Given this list of marker genes Casc3, Ddx39a, Nxf7, Srsf5, Nup155, Nup133, Srsf3, Thoc6, Magohb, Alyref, Nup210, Nup42, Nup85, U2af2, Rnps1, U2af1l4, Nxf2, Nup54, Magoh, Upf3b, Seh1l, Cdc40, Ndc1, Sarnp, Thoc7, Nup58, Thoc3, Nup205, Rae1, Aaas, Nup93, here is a description of the gene set: part of: Transport of Mature Transcript to Cytoplasm species: Mus musculus electronically inferred by orthology from the curated human pathway Reactome Pathway: Transport of Mature mRNA derived from an Intron-Containing Transcript This event has been computationally inferred from an event that has been demonstrated in another species.<p>The inference is based on the homology mapping from PANTHER. Briefly, reactions for which all involved PhysicalEntities (in input, output and catalyst) have a mapped orthologue/paralogue (for complexes at least 75% of components must have a mapping) are inferred to the other species.